The following is a description of a gene set: species: Mus musculus Mouse Gene Set: GOCC_LAMIN_FILAMENT Any of a group of intermediate-filament proteins that form the fibrous matrix on the inner surface of the nuclear envelope. They are classified as lamins A, B and C., and this is the list of marker genes: Narf, Lmna, Lmnb1, Lmnb2, Eif6, Lmntd2